The following is a description of a gene set: Any process that decreases the rate, frequency, or extent of a change in state or activity of a cell (in terms of movement, secretion, enzyme production, gene expression, etc.) as a result of a growth factor stimulus. Mouse Gene Set: GOBP_NEGATIVE_REGULATION_OF_CELLULAR_RESPONSE_TO_GROWTH_FACTOR_STIMULUS species: Mus musculus, and this is the list of marker genes: Thbs1, Adgra2, Mmrn1, Fuz, Tmprss6, Dlx1, Wnt1, Ngfr, Chrd, Skil (NCBI Gene Id 71615), Crim1, Cd59a, Spry1, Erfe, Sostdc1, Cer1, Sema6a, Gata3, Epn2, Sulf2, Slit2, Dand5, Apln, Il12b, Trim33, Rbpms2, Twsg1, Il12a, Lrp2, Skor1, Fstl3, Tmem53, Pdcd6, Grem2, Hipk2, Agt, Fgfrl1, Smurf1, Sfrp2, Hrg, Notch1, Nanog, Ppm1a, Smad7, Tcf7l2, Nog, Mtmr4, Hjv (NCBI Gene Id 99714), Lemd2, Shisa2, Agtr2, Mir675, Ctdspl2, Mmrn2, Dcn, Cxcl13, Spry4, Wnt4, Adamts12, Chrdl2, Dkk1, Cadm4, Sfrp1 (NCBI Gene Id 72362), Sulf1, Htra1, Pparg, Sorl1, Dab2ip, Chrdl1, Bmper, Grem1, Ofd1, Smurf2, Cflar, Hgs, Gdf3 (NCBI Gene Id 97289), Tnfaip6, Emilin1, Abl1, Sost, Gpr155, Nbl1, Skor2, Ptpn1, Atp2b4, Lemd3, Nedd4, Vwc2l, Bambi, Pik3cb, Spry2, Ptprf, Il4 (interleukin 4), Xdh, Tob1, Cnmd, Prdm14, Creb3l1, Fbn1, Vwc2, Cask, Wnt5a, Ski, Hhex, Spart, Smad6, Fzd1, Gpc1, Htra3, Cav1